Given this list of marker genes TMEM158, IFT80, UBASH3B, SNX18, SERINC3, RNPEP, HK2, GSAP, ATP2A2, HOPX, DENND5A, VPS54, ZC2HC1A, STON1, ALOX15B, PLP2, CD274, HNRNPLL, CCDC122, GATA1, UNKL, KHDC1L, ITGAV, SLC2A1, PLCB4, GBP2, CD83, NCF4, MEF2D, PHTF2, RORA, SHE, GOLM2, FRMD6, TMEM64, PRKRA, ANXA4, SLAMF1, DMD, ZNF516, KIF13A, NCMAP, AHCYL2, KLF6, FXYD2, CERK, SOCS2, CCR6, TANC2, RGS1, ACOT7, TNFRSF4, ZBED5, CCR5, FBXO32, SWAP70, PENK, CNKSR3, IL2RA, ODC1, SCPEP1, SUOX, TWSG1, CEP128, PLAGL1, PPM1L, CASP4, DAPP1, WLS, MDFIC, NFAT5, ITGAE, NRP1, TMEM154, MAP3K8, BCLAF3, STIM2, CDK6, NIBAN1, MYADM, PLPP1, WDR45, NIBAN3, RXRA, EBI3, ZDHHC23, DUSP4, TM7SF3, PSMD14, LAD1, ST3GAL2, ATXN1L, C9orf152, C3orf70, MATN2, NCF1, NR3C2, RABEP2, ACOT11, GLRX, CCR2, RASGEF1A (NCBI Gene Id 221002), NEU3, ADAMTS6, ABHD17C, MXD1, SERPINB6, TNFRSF1B, ENTPD1, FNTA, CST7, ZC3H12C, SLC22A5, ARHGAP24, SNORD89, MPRIP (NCBI Gene Id 23164), IMPDH2, ATP9A, NTN4, KLRG1, AXL, HDAC9, FGD6, SEPTIN8, MPP1, BANK1, USP27X, INPP5F, CHAMP1, ARHGAP18, TMEM65, ENDOD1, VPS8, ZNF608, TNFRSF18, CCRL2, PSEN2, AHR, RNF135, SLC9B2, LMAN1, CEMIP2, CISH, IL12RB1, PON2, ANKRD6, GBP4, PHETA2, CORO2A, NOD1, CDCP1, FGL2, AHNAK, IL1RL1, PBXIP1, GUCY1B1, PTPN13, SMAP1, H2AZ1, OSBPL3, REL, CTNNA1, SOAT1, TRIM14, ACADSB, MELK, SDCBP2, DGAT1 (NCBI Gene Id 8694), ZC3H12D, RRAGD, NT5E, IRF8, FOXP3, PHLPP1 (NCBI Gene Id 23239), LCLAT1, TRIM59, SLC2A3, ST6GALNAC4, LAMC1, ITM2C, CPPED1, ZCCHC18, SESN1, DNAH7, F2R, SLC35D1, GPR68, MTMR3, CD81, TBC1D4, IRF4, ARHGAP21, SAMSN1, SH3BGRL, ERGIC1, CD86, NFKBIZ, LRIG1, NDRG1, TMBIM1, here is a description of the gene set: Genes up-regulated in comparison of lymph node regulatory T cells versus lymph node conventional T cells. Comparisons of global gene-expression profiles revealed a greater distinction between CD4+ Treg cells and CD4+ conventional (Tconv) T cells residing in abdominal (epidydimal) fat versus in more standard locations such as the spleen, thymus and LN. species: Homo sapiens from publication Feuerer M, Herrero L, Cipolletta D, Naaz A, Wong J, Nayer A, Lee J, Goldfine AB, Benoist C, Shoelson S, Mathis D (PMID 19633656) Human Gene Set: GSE7852_TREG_VS_TCONV_LN_UP